The following is a description of a gene set: part of: Interleukin-1 signaling; MyD88 cascade initiated on plasma membrane; MyD88:MAL(TIRAP) cascade initiated on plasma membrane; TRAF6 mediated induction of NFkB and MAP kinases upon TLR7/8 or 9 activation; TRIF (TICAM1)-mediated TLR4 signaling ; Toll Like Receptor 3 (TLR3) Cascade studied in species Homo sapiens NF-kappa-B is sequestered in the cytoplasm in a complex with inhibitor of NF-kappa-B (IkB). Almost all NF-kappa-B activation pathways are mediated by IkB kinase (IKK), which phosphorylates IkB resulting in dissociation of NF-kappa-B from the complex. This allows translocation of NF-kappa-B to the nucleus where it regulates gene expression. Reactome Pathway: TAK1-dependent IKK and NF-kappa-B activation, and this is the list of marker genes: N, CHUK, NOD2, TIFA, SAA1, IKBIP, APP, S100B, NKIRAS1, S100A12, TRAF6, TP53 (tumor protein p53), IKBKB, UBE2V1, USP14, TAB1, ALPK1, N4BP1, IRAK2 (interleukin 1 receptor associated kinase 2), TAB2, IKBKG, NLRC5, AGER, LRRC14, MAP3K7, NFKBIB, TAB3, UBA52, NFKB2, NFKB1, USP18, RIPK2, NKIRAS2, UBC, IRAK1, HMGB1, RELA, UBB, RPS27A, UBE2N, NFKBIA, NLRX1, TRAF2, NOD1, CASP8